The following is a description of a gene set: Human Gene Set: HP_SLANTING_OF_THE_PALPEBRAL_FISSURE Slanting of the palpebral fissure species: Homo sapiens, and this is the list of marker genes: ATR, KIF7 (kinesin family member 7), FZR1, NFIA, KPTN, SKIC3, COL3A1, ATAD3A, PHIP, FANCI, SPRED1, ZMPSTE24, CEP290, RPS19, SLC38A3, NOG, MSL3, MKS1, SNRPB, CLTC, SZT2, BRIP1, PPP2R5D, ACBD6, HBA1, TNRC6B, IQSEC2, PHC1, CCDC115 (NCBI Gene Id 84317), ROR2, ASXL3, OTUD5, KCNB1, PALB2, FANCG, DHDDS, PCGF2, MFSD2A, RNF135, SOS1, ABL1, SF3B4, PEX26, CHRNA7, SHOC2, SLF2, CLCN3, PPP1R21, EXOSC2, UFD1, HS6ST2, MCPH1, SMPD4, WAC, KANSL1, WARS1, MAGEL2, PEX12, KMT2E (NCBI Gene Id 84147), WDR62, MYOD1, TRIO, PRKAR1B, CEP152, SNORD116-1, FZD2, UNC80, COL9A3, TRIP12, CDK13, EDEM3, KCNMA1, PRDM13, MECP2, JARID2 (jumonji and AT-rich interaction domain containing 2), NEK9, H4C3, SOS2, DALRD3 (NCBI Gene Id 55152), COLEC11, CHD7, MCTP2, CDK19, BRCA1, NR2F1, PACS1, BBS5, GMNN, BBS2, TAF4, COPB1, NOVA2, EBF3 (NCBI Gene Id 276717), SCNM1 (NCBI Gene Id 79005), PYCR2, AGO1, CTCF, FANCC, PWRN1, IFT140, RAP1B, IFT27, POLR1B, DBR1 (debranching RNA lariats 1), DDB1, RDH11, LZTFL1, DPH1, POLR3GL, TWIST1, SLC13A5 (NCBI Gene Id 284111), DOK7, TGFBR1, FLNA, TRIP13, CLCN4, WASF1, IGBP1 (immunoglobulin binding protein 1), NRCAM, STEEP1, BBS12, HNRNPR, ZFX, C2CD3, TMEM147, FGFR3, FILIP1, TLK2, GABRB2, MTSS2, DYNC1H1, PARS2, ATP7A, MASP1, UBR1, YY1, TBX1, ZBTB20, PEX19, TELO2, PPP1CB, HRAS, BCL11A, CTBP1, RAD51C, LDHD, MID1, DSE, APC, JMJD1C, ABCA5, KDM1A, BRAF, HS2ST1, SETBP1 (NCBI Gene Id 284262), SUPT16H, PLPBP, KAT6B, SLC26A2, CEP63, PUS7, TRMT10A, GALNT2, HBB, MEF2C, HEATR3, GABRA5, IFT172, CHAMP1, H4C5, TMCO1, NFIX, ZEB2 (zinc finger E-box binding homeobox 2), FIBP, LMNB1, CERT1, DOCK3, FLII, TAF1, MVK, GPC4, PHF8, DHCR24, MEGF8 (multiple EGF like domains 8), SUZ12, KIF15, UBAP2L, TGDS, TTC8, UBR7, AGR2, ATP6V1B2, POGZ, DPH2, ZIC1, PEX3 (peroxisomal biogenesis factor 3), AMPD2, COG1, PAFAH1B1, BBS7, HHAT, HDAC4, TOR1A, BUB3 (BUB3 mitotic checkpoint protein), SDCCAG8, SLC2A10, OSGEP, TUBGCP2, DPH5, EIF2AK3, KDM4B, FANCM (NCBI Gene Id 57697), TBCK, CTNND2, KIF11, NXN, SLC39A13, COL5A1, CASP2, NPAP1, HNRNPH1, GORAB, SPIN4 (NCBI Gene Id 139886), TUBB3 (NCBI Gene Id 94749), BRCA2, SETD1B, KMT2A, PIGG, PEX14, TBX6, MINPP1, CEP19, FIG4 (NCBI Gene Id 9896), ACTB, DLG3, RYR1, EFEMP1, CACNA2D1, CIT, RFX7, FLCN, DONSON, WBP4, H3-3A, GNB2, BBS10, U2AF2, PPP1R12A, FBXO28, PTPN11, AHDC1, PHOX2B, PIGN, THOC6, KCNH1, CCDC22, DYNC1I2, NARS1, EXTL3, RIT1, SNRPN, BPTF, RRAS, FBXL4 (F-box and leucine rich repeat protein 4, NCBI Gene Id 26235), CACNA1G, BBS1, SMARCA2, WASHC5, DYRK1A, FOXP1, NOTCH3, RIN2, ALG2, MAPK8IP3, SET, MAD2L2, SMS, BAP1, SPRED2, BUB1B, EFTUD2, TFAP2A, RPS6KA3, KIFBP, BBS4, FANCF, HIRA, POLA1 (NCBI Gene Id 5422), MAN1B1, H4C9, NUS1, CDK6, MAP2K1 (NCBI Gene Id 5604), POLR1D, IFT56, ADAMTSL2, EBP (EBP cholestenol delta-isomerase), ALDH1A2, SETD5, TSR2, SCAPER, YWHAE, CAMK2A, NAA20, PPP1R15B, ADARB1, PIGB, PLOD1, TUBB, TSPEAR, CHD8, PCDHGC4, TRAPPC10, PEX11B, SCLT1, CNKSR2, PEX1, MRAS, GNPNAT1, GLE1, PSMD12, NSRP1, MKRN3, DNM1, RRAGC, SLC29A3, SOX5, SPEN, GJA1, DPYD, SPOP (NCBI Gene Id 8405), NOTCH2, ARCN1, THUMPD1, CDK5RAP2, QRICH1, PYCR1, AARS1, CD96, AP3B1, MAP2K2, EFNB1, CHST3, CKAP2L, TNNI2, LMBRD2, CBL, POLR1A, LTBP1, ZNF148, NAA10, KRAS, ZIC2, CDK10, MED25, PEX16, PACS2, TFAP2B, PRPS1, GSC, ZSWIM6, MN1, CPLX1, BCORL1, CSGALNACT1, RAB11B, RAI1, NCAPD3, TWIST2, PIGY, RPS28, TAF13, ANKRD11, SPTBN1, DYNC2LI1, VPS35L, COG8, AKT1, CENPT (centromere protein T), STAC3, IDH1, OFD1, PURA, CDH11, MPDZ, PQBP1, RECQL4, FBXO31, RNU4ATAC, SIAH1, ARID2, ZNF462, AFF4, PAK3, CHD1, TOE1, KMT2D, ESAM, ZNF292, BRPF1, METTL5, SIN3A (SIN3 transcription regulator family member A), CEP57, OCRL (NCBI Gene Id 4952), IGF1R, PMM2, PIGV, XRCC2, ARVCF, YWHAG, ACTL6B, SNORD115-1, TRRAP, MKKS, SYNJ1, SLC19A3, FBN1, SLC1A2, SCN1A, MED12L, COL11A1, LIG4, TBCD, AUTS2, EXOC2, RLIM, DMXL2, PAX3, FANCB, MAPK1, POLR3A, IL6ST, SASS6, BUB1, DPF2, RTTN, SON, COMT, RAF1, ARL6, ATP1A3, ASXL1, EZH2, HNRNPC, CTU2, ADAT3, KIF14, DLX4, ASPM, KREMEN1, EIF5A, PEX2, CCDC32, FAM20C, NEXMIF, ALX4 (NCBI Gene Id 64068), B3GLCT, ARID1B (NCBI Gene Id 645070), MYMX, SPECC1L, RREB1, CENPE, NECAP1, FGF3, KDM5B, GABRA2, MED12, FGFR2 (NCBI Gene Id 2263), B3GAT3, EFEMP2, COLEC10, TCF4, DDX59 (DEAD-box helicase 59), TRPM3, DHX9, EP300, SMC1A, UMPS, DPP9, GRIN2D, HECTD4, CREBBP, KCNC2, CNOT2, SETD1A, DHODH, UBA5, TGFB3, TGFB2, RASA2, DPM1, PIGW, GAD1, HCN1, PDGFRB, ANK1, PRR12, ANKLE2, DEAF1, FHL1, ITPR1, CACNA1A, ESCO2, ERI1, CRTAP, ATP6V1E1, OTUD7A, ATP1A2, MAF, PWAR1, KCNA2, PEX5, COG7, KAT5, ZNF526, NSD2, RAB3GAP2, CWC27, HUWE1, KDM6A, AFG2B, NSDHL, NFIB, PPP2R1A, CAMTA1, PGAP2, EEF1A2, ORC6, ANKRD17, MGAT2, CHD4, NTRK2, GABRG2, CHD5, BCL11B, GATA4, PIGL, CHST14, CHRNG, MYCN, RIPK4, ACTG1, TBR1, SEC24C, PIGO, GPC3, TRAPPC14, LETM1, BICRA, MEIS2, AP1S1, NUP37, WDR26, PIGT, ZMIZ1, NECTIN1, SEPTIN9, PLK4, ZC4H2, XRCC4, UQCC2, CDH2, FGD1, PEX7, AP3B2 (adaptor related protein complex 3 subunit beta 2), GABBR2, AMMECR1, PTCH1, UBE2T (NCBI Gene Id 29089), IFT57, MYMK, PKDCC, RAPSN, C12orf57, EIF4A2, FLI1, PIGA, BBIP1, HERC2, SEC24D, FANCE, PRRX1 (NCBI Gene Id 5396), SLC45A1, COL11A2, CASK, CYFIP2 (cytoplasmic FMR1 interacting protein 2), MRPS2, H4C11, SMAD2, PITX1, CEP135, STIL, DHX30, PCNT, SATB1, SLC25A24, FANCA, KAT8, HIVEP2, LRP2, BGN, ABAT, SEMA5A, SIM1, ZMYM2, POLR1C, HERC1, AGO2, KCNE5, CDC42, NUP85, RNU4-2, CFAP418, VPS13B (NCBI Gene Id 54990), MAPRE2, PEX10, HBA2 (NCBI Gene Id 3040), ATRX, SYNGAP1, TFE3, GJA8, IL1RAPL1, MYH3, CELF2, DVL1, RAD51, SLC9A7, AP4E1, VAC14, PUF60 (NCBI Gene Id 22827), SCN8A, PGM2L1, SARS1, FBXO11, ASPH, JAG1, KCNN3 (potassium calcium-activated channel subfamily N member 3), HNRNPK, ODC1, MED13L, FANCD2, ADNP, NONO, PPP3CA, FGFR1, TCOF1, NSD1, NRAS, PGAP3, PGAP1, ACSL4, SH3PXD2B, NF1, SLC32A1, ATP6V1A, DVL3, ATP6V0A2, BLTP1, ALDH6A1, PTEN, PEX6 (peroxisomal biogenesis factor 6), IFT74, RRAS2, BBS9, EHMT1, HNRNPU, APC2, BMPR1A, PEX13 (NCBI Gene Id 5194), SC5D, OTUD6B, NPHP1, DHCR7, SCN4A, TRAK1, RAD21, LRP4, NALCN, LMNA, SATB2, GATAD2B, GJA5, RERE, P4HB, FOXG1, WDPCP, UBE3B, EED, TRAIP, SPART, DPYSL5, WWOX, CDC42BPB, KNL1, FREM1, HSD17B4, ADAMTS2, TMEM237, PIK3CA, IL11RA, FGF12, RFWD3, WDR35, MTOR, TRIM32, KDM5A, USP9X, FANCL, UBE3A, ARHGEF2, WNT5A, SLC30A9, GLI3, BMP2, UBE2A, CUL4B, NR4A2, LZTR1 (leucine zipper like post translational regulator 1), DNAJC21, CNTNAP2, TASP1, NELFA, CEP295, NDUFS4, CNOT3, RBBP8, SNAP29, MAP3K7, MCM7, SMOC1, BRD4, SCN3A, SETD2, ZMYND11, ATRIP, ADAMTS3, COPB2, CACNA1B, DNA2, ERCC4, GP1BB, KDM5C, NBN, SLX4, SKI